The following is a description of a gene set: Mouse Gene Set: GOBP_REGULATION_OF_MEMBRANE_INVAGINATION studied in species Mus musculus Any process that modulates the frequency, rate or extent of membrane invagination., and this is the list of marker genes: Alox15, C3, Nckap1l, Ager, Gata2, Stap1, Abca7, Syt11, Fcgr1, Lbp, Rab31, Cd300a, F2rl1, Siglece, Trem2, Appl2, Plcg2, Cd36, Itga2, Ano6, Pparg